The following is a description of a gene set: Protein lipoylation Mouse Gene Set: REACTOME_PROTEIN_LIPOYLATION species: Mus musculus, and this is the list of marker genes: Ndufab1, Lipt1, Nfu1, Dbt, Gcsh, Dlst, Dlat, Lipt2, Lias, Fdx1